The following is a description of a gene set: species: Homo sapiens Human Gene Set: GOBP_POSITIVE_REGULATION_OF_MITOCHONDRIAL_MEMBRANE_POTENTIAL Any process that activates or increases the frequency, rate or extent of establishment or extent of a mitochondrial membrane potential, the electric potential existing across any mitochondrial membrane arising from charges in the membrane itself and from the charges present in the media on either side of the membrane., and this is the list of marker genes: VCP, BID, NNT, NDUFC2, MFN1, BAD, MTLN, PRKN